The following is a description of a gene set: Mouse Gene Set: GOBP_REGULATION_OF_NEUTROPHIL_EXTRAVASATION species: Mus musculus Any process that modulates the frequency, rate or extent of neutrophil extravasation., and this is the list of marker genes: Ptger4, Il1r1, Fut7, Pawr, Cd99l2, Ptger3, Adam8, Mdk, Ripor2